Given this list of marker genes DYRK1A, PDE2A, UBE3A, WDR4, MAPT, OCA2, KANSL1, TTI1, MECP2, ATP10A, GATAD2B, PSEN1, ATRX, GLI3, GRIN1, MBD5, NOVA2, TBC1D2B (NCBI Gene Id 91449), SLC6A17, PIGS, SMC1A, TELO2, GRIK2, HSD17B10, ADSL, SLC9A6, PGAP1, CSF1R, SNRPN (small nuclear ribonucleoprotein polypeptide N), CDKL5, NTNG2, NTNG1, GABBR2, here is a description of the gene set: Laughing that may be excessive and/or inappropriate in context (e.g., laughing at a funeral while others are crying). Human Gene Set: HP_INAPPROPRIATE_LAUGHTER species: Homo sapiens Inappropriate laughter